Given this list of marker genes HNRNPLL, MIR5696 (microRNA 5696), ZNF280D, TTI2, MDH1, OCEL1, ZEB2, MIS18A, WDPCP, LSM3P2, KIF18B-DT, EIF1AD, ZMIZ2, UTRN, PFAS, STAG3L3, ZYX, AKT3, RUFY2, GMPR, ATP1B1, ATOX1, ZNF397, SUZ12P1, NOP58, FANK1-AS1, DBNDD1, TCL6, PCBP1-AS1 (NCBI Gene Id 652470), TRAV39, TENT2, PPP2R1A, EFR3B, ABCG5, ZNF106, CCM2, PDIA6, KIF14, JAKMIP2, CTB-30L5.1, RHOBTB3, IL6, MED18, RN7SL619P, TFCP2, AP2M1, ICA1L, ACVR2A, SNHG16, ZNF114, PAGR1, EMC3, SUB1 (NCBI Gene Id 10923), PTPRR, ERI2, MIR4748, UNKL, WDR26, ENSG00000255240, PRR15, MIR548AA2, SF1, BLOC1S5-TXNDC5, MIR6798, TATDN3, SPA17, TXN2, CREBL2, RGPD8, LINC00518, ZNF184, NPAS1, GLYATL1, TCF4, NFKBID, DROSHA, NDE1, BLOC1S5, SIAE, USP6NL-AS1, KDM4A, ADAR, APOLD1, CEACAM19, ZZZ3, CHMP6, PCYOX1, MIR99AHG, ACTR1B, CYP2D6, SLC29A2, RENBP, DNMT1, SYT12, TIMM9, PSG11, RBM10, TCF12, SLC36A4, DENND3 (NCBI Gene Id 22898), KDM2B-DT, CDC42SE2, CUX2, IRGC, NPTN, MSANTD4, MEF2C-AS2, ASB5, NDUFB11, ENSG00000278356, BNIP5, C17orf100, EGFEM1P, SSBP1 (NCBI Gene Id 6742, single stranded DNA binding protein 1), GSTCD, DBR1, SKIDA1, ERI1, SPRY4, CDKN3, PCNX2, MLLT10, TENM2, ISLR2, CRLF3, AGBL2, LINC02413, TMEM248, EEF2, VPS33B, MTO1, SQSTM1, ZNF197, FBN1, ING3, REPIN1 (replication initiator 1), OSBPL11, ANP32E, SRSF11, LINC01842, MIR4768, UPK1A-AS1, IMPA2, MYNN, STRN4, SLC25A46, ANKRD23, SSR3, BRD8, EEIG2, CLASP1, CLASP2, NDUFA10, ALG10, CALR, NT5M, ZNF536, CRYZL1, CSNK1G3, SPRY4-AS1, FZD9, VDAC3, MYO1E, DCUN1D3, RN7SL183P, CDC23, RPLP0, E2F2, ZNF521 (zinc finger protein 521), ATP6V1E2, MIR5588, CAV2, GLO1, PLEKHO1, APLP2, GYS1, STAT6, FAM21EP, OTUD5, DMAC2L, BANF1, ZNF367, USP54, CSNK1A1, H4C3, CREB1, CREB5, TIMM44, RABL6, C6orf52, HOXA11-AS, RACGAP1 (Rac GTPase activating protein 1), DCTN6, SSU72, PPP1R13L, SF3B3, C2orf92, RNU6-930P, HOXB4, VTRNA1-1, ACP6, MAPK6, DLG1, CS, S1PR1-DT, CAST, SCN3A, GMFB, SLC2A5, ZMAT1 (zinc finger matrin-type 1), TRIR, CCT6P3, MAF, ZNF114-AS1, LCA5, ZNF334, SLC20A2, SCNM1, CDK17 (cyclin dependent kinase 17), ZMYND10, PLA2G12AP1, UBE2D4, MSANTD3, CREBBP, MACROH2A1, BCL11A, MORF4L2, SULT2B1, MTPAP, PAIP2B, HINT2, CTC1, SCN1A, GPLD1, NKX2-5, SAFB2, WDR19, DKKL1, MYBL2, GM2A, UQCC4, SLC12A2, CLIP1, BCAR3, MIDEAS, CRTC2, LHX1-DT, SAT1, LINC00680, BARHL2, ATG12, RAD1 (RAD1 checkpoint DNA exonuclease), GPR85, LIPT2-AS1, MYCBP2-AS1, ZNF596, CNN1, POLRMT, SLC9A3P3, KLK8, SHROOM3-AS1, EFHD1 (NCBI Gene Id 80716), NSL1, TRMT10B, EHBP1 (NCBI Gene Id 23301), ANKFY1, POLR3A, SLC8B1, PHLDB3, TNFAIP8L2, BCL11B, WASHC2A, LYRM4, URI1, SRP72 (NCBI Gene Id 6731), AKAP11, CXorf66, SNHG30, BLVRB, HDAC2-AS2, MTREX, UCK2, SIRT7, RNA5SP21 (NCBI Gene Id 100873276), EFHC1, ZBTB22, HDAC8, BRPF3, SRFBP1, FLVCR1, FAXDC2, C2-AS1, MAP4K1, SLC9A7P1, USP33, PCBP1, MOGS, TRIM27, AFG1L, EBI3, TEAD2, PATL1, TGFBRAP1, ELOC, ATG4C, IRAK1, SUPT5H, IDH3A, MPP2, ENSG00000230960, ITGA5, DNAJC7, REV1, RNU6-1337P, DAZAP2, DDX18P5, NRAV, RGL3, TSTD1, SPRY1, TBC1D5 (NCBI Gene Id 9779), RCAN1, ELF1, ABI1, SAR1A, NUDCD3, MAP3K10, CANT1, XIAP-AS1, ATPSCKMT (NCBI Gene Id 134145), OSBPL1A, WEE2-AS1, TMC5, VASP, MIR4634, TFAP4, GDF5, SNORD13, AGPAT4, USP18, ALKBH4, ENSG00000272384 (novel transcript), ZNF28, RPS20, HPSE2, PRKRIP1, ATG13, HLA-F, JMJD4, ARMT1, PNKP, ALG5, MYO19, GUSBP11, HSPA2, HCG9P5 (HLA complex group 9 pseudogene 5), SEMA6A, RPL21P122, SLU7, ANKRD28, MTRFR, CACNA1A, BMS1P4, FARS2, ATIC, CALD1 (NCBI Gene Id 800), NDST2, TMED7-TICAM2, HS6ST1, RNF149, SGSM3, RCC2, ERVK13-1, ELMO2, APOBEC3D, KATNAL1, BPNT1, NSD2, CAND1 (NCBI Gene Id 55832), COLGALT2, LINC00649, HNRNPL, PF4, ZNF131, HOXB3, LINC01556, H2AC10P, ERAP1, GUSB, MED6, BICRA, TRIM36-IT1, TIAM2, ST13, RNU2-39P, NOP56P1, ODF2L (outer dense fiber of sperm tails 2 like), CACNB2, UBE2T, DHX29, TNRC6A, HOOK2, SYNM, SYNGR2, ADGRL1, PXN-AS1, GOLM2P1, MAFTRR, CTDSPL, DNASE1, IGF2BP1, VHLL, ZBTB6, ERCC1, GNAI2, TINF2, KRT19, TFF3, PLBD2, BTRC, AFF4-DT, TGIF1, GTF2I, DDX27, IGF2BP3, CCDC138, LINC00173, NRBP1, DELEC1, PPFIA1, TTLL5, COL5A1, ARHGAP45, EXOSC8, ARPC3, CREM, STARD7, BARHL1, GDI2 (GDP dissociation inhibitor 2), ABI3BP, NICN1, LNC-LBCS, NMB, CISD2, NDUFA6-DT, TMEM161B, SPRED2, PLPP3, TACSTD2, FKBPL, NAA25, PIK3IP1, PLA2G4C, H3C8, MORF4L2-AS1, POLD3, DCAF1, CELF4, KLC4, SLC12A2-DT, ZNF417, SLC9A1, SAPCD2, RBPJ, MFN1, EN1, FLJ46284, XRCC5 (NCBI Gene Id 7520), CDC42BPA, CCNI, ZIC2, CLN3, TRIB3, DRAM1, TMEM74B, NCAPH, MCUB, PRDM16, RBMS2, NTNG1, RAD51B, TOMM40L, SARAF, S1PR1, ZNF689, C20orf96, HNRNPA1L2, SYTL2, ENSG00000247416, AP2S1, CCN2, ME2, ODF4, MAP3K7CL, ERG28, TMED7, RMND1, PCAT19, TRIM11, MIR615, PSMB2, MAFF, CCT5 (chaperonin containing TCP1 subunit 5), JADE1, RHOQ, NAB1, SIN3A, ATF1, FUZ, TNS2-AS1 (TNS2 antisense RNA 1), AKNAD1, TBC1D25, ANAPC16, RNU6-879P, HOXD11, FAM167A, WDR43, RAB26, VKORC1, RPL39L (ribosomal protein L39 like), RBM39, LHX1, RPL32P26, VHL, FBXO16, TRABD2A (TraB domain containing 2A), RHNO1, PSMD10P1, CTH, FKRP, C4orf3, TRAPPC6B, H2BC10, AMBN, SRRM1, GART, STAG2 (STAG2 cohesin complex component), ST8SIA5, DST, RNF103, ENSG00000259118, MARCHF2, PARP2, IFI44L, STIL, LPIN1, AHSA1, DALRD3, ADAM19, TYK2, FBN1-DT, MKI67, RABGEF1, BABAM1, PFKFB2, MED28, METTL16, IMPG1, GLUD1P3, PIH1D1, THG1L, C1orf43, TCF3, SEMA3A (semaphorin 3A), NLGN1, IL13RA1, ZNF638, ANKRD31, PNO1, SNAP23, LINC00598, SV2B, AKT2, TPRA1, SGF29, NIFK-AS1, JADE2 (jade family PHD finger 2), BCL6, RN7SL535P, ZNF506, CPSF2, MCL1, SLC33A1, RPL23AP53, RBM5, JPT1, SPINT1-AS1, MZF1, BRAT1, NFAT5, LINC02384, UQCC1, YOD1, DIP2C, GMNC, RPP38-DT, WWP1, PSMB4, TLR5 (NCBI Gene Id 95519), SPOP, LRWD1, STAR, ZEB2-AS1, FANK1 (fibronectin type III and ankyrin repeat domains 1), LYRM1, ARID5A (NCBI Gene Id 10865), ANKRD39, SYNRG, VAMP8 (vesicle associated membrane protein 8), TOR1B, FAM133B, NR4A2, SLC17A5, CALM2, MSX2, KLHDC10, MIGA1, COQ3, KDM2B, FAM186A, DPYSL3, PMM1, CORO1B, RWDD2B, FAM13B, MAP3K13, ENSG00000202343, RPS9, HARBI1, XPNPEP3, TPTEP2, CYP20A1, YKT6, PPP5C, STIP1, here is a description of the gene set: Genes containing one or more binding sites for (ZNF362) in their promoter regions (TSS -1000,+100 bp) as identified by GTRD version 20.06 ChIP-seq harmonization. studied in species Homo sapiens from publication Yevshin I, Sharipov R, Kolmykov S, Kondrakhin Y, Kolpakov F (PMID 30445619) Human Gene Set: ZNF362_TARGET_GENES